Given this list of marker genes Frem1, Garem2, Cd200, Ints15, Zw10, Ap1ar, Arfip2, Ern1, Col10a1, Cox14, Pax3, Nav1, Cnep1r1, Gys1, Rimoc1, Rab5b, Sirt1, Cyp2j6, Copa, Sgms1 (NCBI Gene Id 98153), Pias3, Strn, Natd1, C9orf72, Mical2, Esrrg, Amacr, Pde1c, Frmd7, Ppp3r2, Car10, Gja3, Erp44, Calcr, Mbtd1 (NCBI Gene Id 217110), Stam, Ralgds, Epb41l3, Mdga2, Mecom, Lrch1, Ptch2, Polq, Lamp2, Gm3985, Nipal3, Usp33, Smco4, Mat2a, Rspry1, Smarcd1, Tmprss15 (NCBI Gene Id 353032), Gnai1, Eif3a, Hacd2, Rfx4, Ctxn1, Map4k5, Sgpp1 (NCBI Gene Id 81535), Bpnt2, Srsf11, Hs1bp3, Tshz1, Tm4sf1, Slco2a1, Tln2 (talin 2), Fkbp14, Gss (NCBI Gene Id 98903), Pgr, Lrrc8c, Asph, Slc11a2, Cc2d1b, Prrg3, Tigar, Fscn1 (fascin actin-bundling protein 1), Plekhf1, Mylip, Stx7, Lyrm9, Cenpo, Usp15, Zfp935, Map3k1, Nfatc3, Nup42, Cep350, Pafah1b1, Zdhhc8, Ddx4, Zfp36l1, Mgat4a, Gnao1, Klhl24, Mfsd14a (major facilitator superfamily domain containing 14A), Kcnq5, Tbx20, Vps35, Slc4a7, Cntn4, Tomm7, Myl12a, Elmo2 (engulfment and cell motility 2), Prkg1, Tfec, Pip4p2, Hdac7, Itprip, Glrb, Six4, Septin10, Kcns2, Mgarp, Ifi213, Mc2r, Ces2e, Trib3, Dab2, Mthfd1, Itsn1, Ccdc9b, Gtf2i, Acsl4, Mtcp1, Fcsk, Snta1, Pik3c2g, Mfsd1, Efhc1, Snx27, Sp1 (trans-acting transcription factor 1), Utp15, Nr2e1, Fhip1b, Creb5, Nr3c2, Tbc1d15, Cep57l1, Arhgap28, Ccdc177, Ddx24, Dctd, Lrfn2, here is a description of the gene set: studied in species Mus musculus Genes predicted to be targets of miRBase v22 microRNA mmu_miR_3544_5p in miRDB v6.0 with MirTarget v4 prediction scores > 80 (high confidence targets). Mouse Gene Set: MIR_3544_5P from publication Chen Y, Wang X (PMID 31504780)